The following is a description of a gene set: from publication Chen Y, Wang X (PMID 31504780) Human Gene Set: MIR642A_5P Genes predicted to be targets of miRBase v22 microRNA hsa-miR-642a-5p in miRDB v6.0 with MirTarget v4 prediction scores > 80 (high confidence targets). species: Homo sapiens, and this is the list of marker genes: UBR5, GCSAM, MTX3, IL5, PXK, PCNP, UFM1, TNFRSF13B, TMEM81, SOWAHA, GTF2H1, INA, NLRP5, SZRD1, NSL1, ARL11, ZNF25, BRD2, HM13, FAM78B, SIX3, KLHL23, MBNL3, LYZL1, KCNQ2, ZBTB20, BBS9, MEF2D, ZNF728, SUZ12, MSI2 (musashi RNA binding protein 2), PTP4A2, MAP3K2, ARRDC3, MFSD4A, DTHD1, TRPM8, SOHLH1, GJA5, ARHGAP39, SP8, BRINP3, NCK2, CLCN3, CMTM4, GAD1, ITPRIPL2, EEF2, SPINT2, FAM199X, ERBB4, TNS1, SEC24A, SRSF6, LUZP1, KAT2A, PPARGC1A, ARIH1, C21orf91, HECTD3 (HECT domain E3 ubiquitin protein ligase 3), KRT85, PRKCD, BDH1, RASSF10, SMCO4, KCTD8, PTK7 (NCBI Gene Id 5754), CHL1, ZNF705A, MTRFR (mitochondrial translation release factor in rescue), GALNT7 (polypeptide N-acetylgalactosaminyltransferase 7), APMAP, PLPPR4, STRAP, INO80, LMO4, ZNF37A, HECA, SNX3, EPM2AIP1, MAP3K7, TANC1, HTR1F, GDA, FLVCR2, C1GALT1, RAMAC, KLF5, TM9SF3